Given this list of marker genes Rapgef4, Fgf12, Tnr, Mtnr1b, Chrnb2, Chrna5, Tymp, Il6, Avp, Glra1, Ghrl, Chrnb4, Cartpt, Kcnc4, Ghsr, Cntnap2, Agt, Pawr, Gpr35, Gba1, Hcrt, Itga2, Trpa1, Fmr1, Ifng, Avpr1a, Ffar3, here is a description of the gene set: studied in species Mus musculus Any process that modulates the frequency, rate or extent of transmission of a nerve impulse, the sequential electrochemical polarization and depolarization that travels across the membrane of a neuron in response to stimulation. Mouse Gene Set: GOBP_REGULATION_OF_TRANSMISSION_OF_NERVE_IMPULSE